The following is a description of a gene set: Directly binding to and delivering copper ions to a target protein. species: Mus musculus Mouse Gene Set: GOMF_COPPER_CHAPERONE_ACTIVITY, and this is the list of marker genes: Atp7a, Atox1, Park7, Sco2, Cox17, Ccs